The following is a description of a gene set: Elevated circulating hepatic transaminase concentration Elevations of the levels of SGOT and SGPT in the serum. SGOT (serum glutamic oxaloacetic transaminase) and SGPT (serum glutamic pyruvic transaminase) are transaminases primarily found in the liver and heart and are released into the bloodstream as the result of liver or heart damage. SGOT and SGPT are used clinically mainly as markers of liver damage. Human Gene Set: HP_ELEVATED_CIRCULATING_HEPATIC_TRANSAMINASE_CONCENTRATION species: Homo sapiens, and this is the list of marker genes: ALDOB, KIF12, SLC25A20, IRF2BP2, CD81, AHCY, HSD3B7, IFT56, IFT74, BMP2, DNAJC19, NSMCE2, TFR2, BBS5, COG7, HACD1, SDCCAG8, TRAPPC11, LIPA, ATRX, VIPAS39, AKR1D1, BBS4, KIAA0586, TRMT10C, ALG11, HNF4A, ABCD1, BBS7, PRKCD, HMGCL, MYO5B, TGFB1, C1QBP, SLC9A3, CEACAM6, ALDOA, AP1B1, IARS1, RABL3, EARS2, NR1H4, HMGCS2, SEMA4D, TFAM, ACOX2, LYN, STOX1, ATP8B1, PIGL, LDHA, MST1, MRPS2, PEX14, GYS2, COG5, MKKS, MTX2, MARS1, CFTR (NCBI Gene Id 1080), SUCLG1, UBR1 (NCBI Gene Id 64703), ADA2, GPR35, CEP290, SRD5A3, RNASEH2C, ABCG5, FLT1, DPM1, XK, PALB2, APOB, IER3IP1, MRPS28, RRAGC, COQ4, ADAR, ACSL5, CD19, DCTN4, PNPLA2, HELLPAR, USP53, SLC30A10, CLCA4, SLC22A5, B4GALT1, STEAP3, IFT172, HFE, IFT27, PYGL, HSD17B4, ACADM, PEX16, SLC51B, TMEM199, SMAD4, CLPB, TNFRSF13C, CSPP1, COG2, DLD (NCBI Gene Id 2654), SAR1B, RNF220, ABHD5 (NCBI Gene Id 51099), GNMT (NCBI Gene Id 27232), G6PC1, YARS2 (NCBI Gene Id 51067), F5, ZNFX1, MT-CO1, POLD1, GLRX5, MRPL44, LIPT1, LZTFL1, SERPINA1, CCDC115, MICOS13, GIMAP5, TANGO2, BCAP31, FOCAD, ADK, BSCL2, VPS33B, SLC11A1, DEF6, POLG, AGPAT2, TTC8, OTUD5, USP18, SAMHD1, DPM3, TRMU, UGT1A1, MVK, VPS13A, TMEM165, PEX2, TWNK, GNE, MLIP, STAT2, TKFC (triokinase and FMN cyclase), CDKN2A, RAG1, PHKB, CPT2, FHL1, MRPL3, MIF, EFL1, ERCC4, PCK1, SMPD1, FARSB, BAAT, ALMS1, GSTM3, CFAP418, ERCC6, CFI, UNC13D, IL36RN, CEP164, GBA1, CAV3, POLG2, SLC51A, TNFRSF13B, PMM2 (NCBI Gene Id 5373), ATM, HLA-DQB1, RNU7-1, KIF23, PSMB9, CAVIN1, GPD1, DPAGT1, NOS3, DOLK, ATP6AP1, LBR, CR2, RPGRIP1L, LYST, BRCA1, NFKB2, CORIN, PCYT1A, HLA-DQA1, NBAS, BBS9 (Bardet-Biedl syndrome 9), SBDS, EDNRA, ACAD9, DOCK2, RNASEH2B, SLC35A2, TRIM32, TNFSF12, GDF2, OCLN, LARS1, SP110, LYRM4, RRM2B, ALG12, STX5, SEMA7A, FAH, FBP1, ARL6, ABCB4, PRIM1, ERCC8, CEP19, OBSCN, SLC26A9, WDPCP, ICOS, PRF1, DPM2 (NCBI Gene Id 8818), LSM11, RACGAP1, FADD, DGUOK, SDHD, BBS10, PHKA2, TREX1, ABCD3 (ATP binding cassette subfamily D member 3), OCRL, ASL, COG6, ATP7B, BRCA2, CPT1A, SLC37A4, WRN, LARGE1, BICRA, STX11, DMD, MT-CO3, BBIP1, SLC25A4, EIF2AK3, GALT, BCS1L, BBS1, CALR, APOE, TCF4, COG4, SCLT1, RBCK1, NGLY1, ACOX1, KCNN4, MPV17, HADH, PALLD, CEACAM3, HADHA, STAB1, WDR35, COG8, LPIN1, LMNA, FBXL4, SRP54, JAG1, RINT1, TMEM67, BCAT2, AP1S3, TYMP, PGM1, ABCG8, AGL, MTTP, LIG3, ACADVL, ASAH1, DHDDS, DDOST, PSMB8, HAMP, ACSF3, CC2D2A, MOGS, BBS2, SH2B1, UQCRB, MRPS16, TULP3, STXBP2, HPD, SPTBN1, RAG2, CNOT1, FOXP3, DNAJC21, DCDC2, ALG8, FARSA, PEX19, OTC, PEPD, HADHB, CD46, STX1A, SLC2A2 (solute carrier family 2 member 2), ATP6AP2, NPHP1, NFS1, RNASEH2A, MED12, COX5A, MTM1, PPOX, CYP7B1, OFD1, ALG6, PKHD1, NFKB1, PHKG2, MKS1, PEX13, AMACR, SLC7A7, MYH9, CYC1, INPP5E, GCLC, MICU1, FAN1, HJV, LHX1, SLC25A13, DPYS, GAA, IKZF1, GGCX, HLA-B, JAK2, SC5D, IFIH1, RRM1, HMGCR, HNF1B, TP53, CFH, UQCRC2, COX16, VPS50, SCO1, BBS12 (Bardet-Biedl syndrome 12), MS4A1 (NCBI Gene Id 931), IL18BP, AIFM1, KRAS, SLC6A14, ABCB11, HMOX1, CBS, SCAPER, PSMB4, ALAS2, SLC25A15